The following is a description of a gene set: species: Mus musculus Mouse Gene Set: chr8A2, and this is the list of marker genes: Gm31983, 2310008N11Rik (NCBI Gene Id 72316), Rab11fip1, Nudc-ps1, 1700008N11Rik, Gm24992, Defa-ps10, Polb, Defa29, Gm7807, Gm21092, Ap3m2, Gm20797 (NCBI Gene Id 100039061), Defa17, Ankrd69, Defa33, Ckap2, Chrna6, Kat6a, Defa25, Defa-ps17, Gpat4, Gm31784, 5430430B14Rik, Ido1, Gm17484, Dkk4, Defa5, Gm15816, Gm30692, 5830408C22Rik, Adam9, Ccdc70, Defa-ps1, Defb33, Potefam3a, Hgsnat, Ddhd2, Defa-ps18, Defa30, 1700047A11Rik, 1700041G16Rik, Defa-ps6, Got1l1, Zmat4, Letm2, Defa28, Ido2, Gm8110, Gm21182, Adam32, Slc25a15, Bag4, Mir486, Gm31727, 4933416M07Rik, A730045E13Rik, Defb35, Slc20a2, Gm20796, Erlin2, Fnta, Gm15304, Gins4, Rpl30-ps2, Ank1, Thsd1, Golga7, Defb11, 9130214F15Rik (RIKEN cDNA 9130214F15 gene), Defb1, Defa2, Defa-ps8, Defa24, Gm36879, Eif4ebp1, Fgfr1, Gm17491 (NCBI Gene Id 100502938), Svet1, Mrps31, Defb9, Ccnq-ps2, Gm15313, Plpbp, Gm10689, Tex24 (NCBI Gene Id 74289), Alg11, Chrnb3, Adgra2, Nek5, Star (steroidogenic acute regulatory protein), Gm6009, Gm39147, Adrb3, Defa36, Gm21112, Gm2869, Gm15309, 6430710M23Rik, Gm15056, AY761185, Vdac3, Defa3, Hook3, Gm19164, Gm8096 (predicted gene 8096), Gm24202, Nek3, D830025C05Rik, Ikbkb, Gm24423, Gm45572, Brf2, Defb13, Defa22, Gm32050, Adam18, Gm15314, 2610005L07Rik, Gm15316, Defa38, Defb15, Nsd3, Defa-ps11, Htra4, Thap1, 5430421F17Rik, Gm8100, Ash2l, Tcim, Mir3107 (NCBI Gene Id 100526510), Gm20945, Potefam3b, Defa31, Defb10, Defa23, 6820431F20Rik, Defa37, Defa21, Gm7869, Gm26795, Gm32389, Zfp703, Tpte, Defa40, Defa26, Defa41, Vps36, Defa39, Unc5d, Defa34, Tacc1, Plat, Gm24735, Gm16159, Rnf170, Gm26208, Gm32098, Gm6689, Gm15346, Defb2 (defensin beta 2), Gm24335, Gm10043, Defb50, Gm9911, Kcnu1, Gm15303 (NCBI Gene Id 665969, predicted gene 15303), Gm15312, B230112G18Rik, Proscos, Defa27, Defa42, Gm32567, Plpp5, Sfrp1, Plekha2, Nkx6-3, Mir8108, Gm30978, Gm6040, Adam3, Gm39149, Gm15302, Adam5, Defa35, 1810012K16Rik, Defa-ps16, Defa32, Gm20946, Smim19, Lsm1, Fam90a1a, Defa43, Pomk, Tm2d2 (TM2 domain containing 2), Defa20 (NCBI Gene Id 68009), Atp7b, Gm45370, Gm45470